The following is a description of a gene set: Binding to a fibroblast growth factor. Mouse Gene Set: GOMF_FIBROBLAST_GROWTH_FACTOR_BINDING species: Mus musculus, and this is the list of marker genes: Cxcl13, Hspa9, Fgfr4, Scn5a, Api5, Smn1, Gpc1, Cep57, Glg1, Fgfr3, S100a13, Ptprz1, Fgfr1, Tgfbr3, Fgfbp1, Itgav (NCBI Gene Id 76358), Fibp, Fgfr2, Fgfrl1, Kl, Itgb3, Fgfbp3, Rps19, Thbs1, Rps2, Klb